Given this list of marker genes SLX1A, FANCG, RPA3, FAN1, FANCB, FANCD2, FANCF, RPA1, SLX1B, CENPX, FAAP24, FANCA, FANCL (FA complementation group L), UBE2T, FANCC, RPA2, ATRIP, UBC, EME2, FAAP100, SLX4 (NCBI Gene Id 84464), UBA52, FANCE, MUS81, DCLRE1A, USP1, FANCM, POLN, WDR48, FAAP20, UBB, ATR, ERCC4, DCLRE1B, CENPS, EME1, FANCI, ERCC1, RPS27A, here is a description of the gene set: Fanconi Anemia Pathway Human Gene Set: REACTOME_FANCONI_ANEMIA_PATHWAY studied in species Homo sapiens